Given this list of marker genes CCNA1, TERF1, GAR1, NOP10, ACD, RUVBL1, NHP2, PPP6C (NCBI Gene Id 96749), SHQ1, RTEL1, ANKRD28, TINF2, DKC1, RUVBL2, TERF2IP, PIF1, PPP6R3, WRAP53, TERT, CDK2, CCNA2, TERF2 (NCBI Gene Id 7014), POT1, here is a description of the gene set: Reactome Pathway: Telomere Extension By Telomerase species: Homo sapiens part of: Extension of Telomeres Humans, like most eukaryotic organisms, add direct repeats to the telomere using a specialized DNA polymerase called telomerase. Telomerase is a ribonucleoprotein (RNP) complex minimally composed of a conserved protein subunit containing a reverse transcriptase domain (human telomerase reverse transcriptase, hTERT) and a template-containing RNA (human telomerase RNA component, hTERC, or hTR, hTER). The primer for telomerase is the G-rich single-strand overhang at the chromosome end. <br><br>Telomerase can perform multiple rounds of repeat synthesis. The reaction cycle has been inferred from in vitro studies of telomerase from multiple organisms and can be described as having four events: 1) DNA primer recognition, 2) RNA template alignment, 3) elongation, and 4) translocation. Telomeric DNA is recognized in part by a presumed "anchor site" in hTERT, which preferentially binds G-rich DNA, and this interaction can affect elongation and translocation steps. This interaction occurs 5' of the alignment of the RNA template with the end nucleotides of the chromosome. RNA alignment positions the template adjacent to the chromosome terminus. During elongation, the template directs sequential addition of nucleotides to the telomere end. After synthesis of a repeat is completed, relative movement of telomerase and the primer, termed translocation, repositions telomerase at the end of the newly added sequence to allow initiation of another round of repeat addition.